The following is a description of a gene set: studied in species Homo sapiens Reactome Pathway: Activation of HOX genes during differentiation Hox genes encode proteins that contain the DNA-binding homeobox motif and control early patterning of segments in the embryo as well as later events in development. Mammals have 39 Hox genes arrayed in 4 linear clusters, with each cluster containing 9 to genes. Based on homologies, the genes have been assigned to 13 paralogous groups. The nomenclature of Hox genes uses a letter to indicate the cluster and a number to indicate the paralog group. For example, HOXA4 is the gene in cluster A that is most similar with genes of paralog group 4 from other clusters. <br>One of the most striking aspects of mammalian Hox gene function is the mechanism of their activation during embryogenesis: the order of genes in a cluster correlates with the timing and location of their activation such that genes at the 3' end of a cluster are activated first and genes at the 5' end of a cluster are activated last. (5' and 3' refer to the transcriptional orientation of the genes in the cluster.) Because development of segments of the embryo proceeds from anterior to posterior this means that the anterior boundaries of expression of 3' genes are more anterior (rostral) and the anterior boundaries of expression of 5' genes are more posterior (caudal). Expression of HOX genes initiates in the posterior primitive streak at the beginning of gastrulation at approximately E7.5 in mouse. As gastrulation proceeds, further 5' genes are sequentially activated and they too undergo the same chromatin changes and migration. After formation of the axis of the embryo, similar waves of activation of HOXA and HOXD clusters occur in developing limbs beginning at about E9. Retinoids, especially all trans retinoic acid (atRA), participate in initiating the process via retinoid receptors. Other factors such as FGFs and Wnt, also regulate Hox expression. After activation, Hox genes participate in maintaining their own expression (autoregulation), activating later, 5' Hox genes, and repressing prior, 3' Hox genes (crossregulation). Differentiation of embryonal carcinoma cells and embryonic stem cells in response to retinoic acid is used to model the process in vitro. <br>Activation of Hox genes is accompanied by a change from bivalent chromatin to euchromatin. Bivalent chromatin has extensive methylation of lysine-9 on histone H3 (H3K9me3), a repressive mark, with interspersed punctate regions of methylation of lysine-4 on histone H3 (H3K4me2, H3K4me3), an activating mark. Euchromatization initiates at the 3' ends of clusters and proceeds towards the 5' ends, with the euchromatin migrating to an active region of the nucleus. This change in chromatin reflects a loss of H3K27me3 and a gain of H3K4me2,3. Polycomb repressive complexes bind H3K27me3 and are responsible for maintenance of repression, KDM6A and KDM6B histone demethylases remove H3K27me3, and members of the trithorax family of histone methylases (KMT2A, KMT2C, KMT2D) methylate H3K4. part of: Developmental Biology, and this is the list of marker genes: H2BC5, H2BC15, CTCF, H2AC7, HOXD1, H2BC21, POLR2A, EGR2, POLR2J, HOXB1, H2AX, H2BC12L, H2BC17, PIAS2 (protein inhibitor of activated STAT 2), HOXD3, NCOA6, POLR2H, H2BC12, RBBP7, CNOT9, YY1, H2AC20, H2BC1, HOXB3, HOXB2, H2BC11, H2BC4, EP300, PAXIP1, RBBP4, HOXC4, H2AJ, H2AZ2, WDR5, POLR2I, NCOR1, POLR2K, H2AC6, ASH2L (ASH2 like, histone lysine methyltransferase complex subunit), H2BC14, HOXD4, PAGR1, H2AB1, CREBBP, MAFB, NCOA3, H2BC9, RBBP5, POLR2D, ZNF335 (NCBI Gene Id 63925), POLR2B, DPY30, HOXA4, HOXA1, H3-3A, AJUBA, POLR2E, PKNOX1 (PBX/knotted 1 homeobox 1), POLR2C, H4C1, MEIS1 (NCBI Gene Id 4211), H2BC13, H2AC14, HOXA2, H3C15, HDAC3, H3C1, POLR2F, KMT2C (lysine methyltransferase 2C), KMT2D, H2BC3, H2BC26, PCGF2, HOXA3, SUZ12, RXRA, POLR2G, RARB, RARG, JUN, KDM6A, H2AC18, EZH2, RARA, HOXB4, EED, PBX1, CNOT6, H2AC4, PAX6, POLR2L